Given this list of marker genes HSD17B2, HSD17B1, HSD17B14, HSD17B11, AKR1B15, CYP19A1, here is a description of the gene set: Estrogen biosynthesis Human Gene Set: REACTOME_ESTROGEN_BIOSYNTHESIS studied in species Homo sapiens